Given this list of marker genes YAP1, LIF, PAX2, WWTR1, STAT1, PAX8, here is a description of the gene set: Human Gene Set: GOBP_METANEPHRIC_NEPHRON_TUBULE_EPITHELIAL_CELL_DIFFERENTIATION The process in which relatively unspecialized cells acquire specialized structural and/or functional features that characterize the cells of the metanephric nephron tubule as it progresses from its formation to the mature state. species: Homo sapiens